The following is a description of a gene set: Mouse Gene Set: DESCARTES_ORGANOGENESIS_EPENDYMAL_CELL studied in species Mus musculus Mouse Organogenesis Cell Atlas (MOCA) DE_gene_main_cluster.csv, fold.change>=1.5, qval<0.05, pval<0.05 from publication Cao J, Spielmann M, Qiu X, Huang X, Ibrahim DM, Hill AJ, Zhang F, Mundlos S, Christiansen L, Steemers FJ, Trapnell C, Shendure J (PMID 30787437), and this is the list of marker genes: Drc7, Ccdc170, Gm1110, Pacrg, Cfap44, Efhc2, Dnaaf4, Tsnaxip1, Gmnc, 4930444P10Rik, 3300002A11Rik, Nme5, Wnt8b, Ins2, Slc4a10, Spaca1, Slc13a4, Slc7a10, Ccdc148, Cfap251, Cfap61, Dnah12, Ism2, Wnt9a, Gm5432, Folr1, Eno4, 1700010K24Rik, Abcg8, Gm4540, Tekt1, Cfap126, Fam161a, Folr2, Cracdl, Ttll3, Ccno, 4933408N05Rik, Dnaaf11, Efhb, Ccdc13, Cfap74 (cilia and flagella associated protein 74), Ezr, Rbm47, Ttc12, Ak9, Kif27, Catip, Armh1, Tmem267, Trpm3, Foxj1, Dkk3, Cdhr18, Ccdc187, 1700088E04Rik, Gm36879, Cfap45, Efcab2, Gm28729, Armc3, Gm44196, Ddit4l, Lrrc43, 9130230L23Rik, Ift22, Clic6, Pthlh, Ccdc149, Dnai3, Cfap65, Nek11, Gm15689, Lmx1a, Sec31b, Cfap97d2, Clmn, Htr2c, Katnip, Dcdc5, Nek10, Odad1, Vwa3a, Spag17, Kif9, Fam81b, Cx3cl1, Cfap54, Ccdc65, Pef1, Ankrd45, 3100003L05Rik, Cfap47, Gm12930, Frmpd4, Stk36, Rspo1, Drc3, Arhgef33, Efcab12, Pih1d2, Iqca1, Dusp14, Map3k19, Spef1l, 9330154J02Rik, Tex47, Ankef1, Acss3, Ecrg4, Capsl, Slc6a15, Dnah7c, Gm32926, Ube2u, Ppil6, Fank1, 1700008O03Rik, Spag6l, Dynlrb2, Kcnj13, Caps2, Rspo3, Ttll9, Slco1b2, Notch2, Iqck, Slco1a4, Rph3al, Rsph3b, Ccdc30, Wdr19, Stpg1, Cfap91 (NCBI Gene Id 320214), Kif6, Cfap210, Or10k2, Gm30504, Lrriq1, Agbl2, Rsph4a, Katnal2, D130043K22Rik, Ankrd66, Wdr49, Daw1, Dnai4, E2f7, Syt10, Mdh1b (NCBI Gene Id 98631), Wls, Slc2a12, Dnai1, Cfap70 (cilia and flagella associated protein 70), Svopl, Gm29538 (predicted gene 29538), Spata17, Cfap73, Ccdc157, Efcab6, Ankrd69 (ankyrin repeat domain 69), Calml4, Bmp6, Gm26725, Dlec1, Mcidas, Cfap119, Ulk4, Hydin, Tcte1, Tmem72, Spef2, Ak8, Arsg, Cfap52, Dnaaf3 (NCBI Gene Id 436022), Shisa8, Ift70b, Bbs9, Nsun7, Slc16a2, Zbbx, Slco1c1, Gm10649, Cfap206 (NCBI Gene Id 69329), Iqcg, Spag16, 5430402P08Rik, Dnai2, Enkur, Cfap95, Odad3, Lekr1, Gm20276, Vwa5b1, Ak7, 1700086L19Rik, Marchf10, Rpgrip1l, Hoatz, Cfap36, Wdr93, Dnah7a, Fam149a, Trp73, Dnah7b (dynein, axonemal, heavy chain 7B), Cfap69, Dynlt5, Scrn2, Ccdc81, Lrrc23, Ccdc146, Odad4, Smkr-ps, Ddo, Mycbpap (MYCBP associated protein), Gm16090, Ccdc39, Slc5a3, 4933406B17Rik, Cfap43, Morn3, Nme9, Ttc21a, Cdhr3, Cfap46, Iqub, Dync2i2, Ttr, Meig1, Cfap221, Dnah6, Zfp804b, Ccdc162, Spag8, Gm13266, Esyt3, Efhc1, Igfbp2, E330012B07Rik, Drc1 (dynein regulatory complex subunit 1), Trhr, Dydc2, Abca4, 6820408C15Rik, Gm10735, Fam81a, Iqcd, Mzf1, Ribc2, Erich2, Wnt3a, Vat1l, Dnah3, Chil5, 2810403D21Rik, Crocc2, Ccdc113, Lrguk, Pidd1, Zkscan7, Wfikkn2, Ppp1r42, Ttc29, Vwa3b, Dpy19l2, Odad2, Slc14a2 (solute carrier family 14 (urea transporter), member 2), Fbxo36, Gm4876 (predicted gene 4876), Cdc20b, Cfap53, Kcne2, Ttll6, Ccdc180, Dcdc2a, C630043F03Rik, Ush2a, Pcp4l1 (NCBI Gene Id 66425), Abcg5, Nek5, Gm20172, D930007P13Rik, Pms2, Morn1, 2310014F06Rik, Dnai7, Armc2, Rnf182, Trp53cor1, Mapk15, Fhad1, Saxo2, Gm42722, Ccdc60, B230206L02Rik, Stox1 (NCBI Gene Id 216021), Deup1, Spata18, Mlf1 (myeloid leukemia factor 1), Ubxn11, Epcip, Rsph1, Agbl4, 2610204G07Rik, Lca5l, Cfap161, Mansc4, Shroom3, Rspo2, Tcp11